The following is a description of a gene set: species: Mus musculus Human Gene Set: GRAESSMANN_RESPONSE_TO_MC_AND_DOXORUBICIN_DN Impairment of the complex regulatory network of cell death and survival is frequently the reason for therapy resistance of breast cancer cells and a major cause of tumor progression. We established two independent cell lines from a fast growing mouse breast tumor (WAP-SVT/t transgenic animal). Cells from one line (ME-A cells) are sensitive to apoptotic stimuli such as growth factor depletion or treatment with antitumor agents (e.g. doxorubicin). Cells from the second line (ME-C cells), which carry a missense mutation at the p53 codon 242, are very insensitive to apoptotic stimuli. Co-cultivation experiments revealed that the ME-C cells mediate cell death resistance to the ME-A cells. Microarray and Western blot analysis showed that osteopontin (OPN) is selectively overexpressed by the ME-C cells. This glycoprotein is the most abundant protein secreted by the ME-C cells and we obtained strong indications that OPN is the main antiapoptotic factor. However, the OPN containing ME-C cell medium does not alter the expression level of pro- or antiapoptotic genes or known inhibitors of apoptosis (IAPs). Its signaling involves mitogen-activated protein kinase (MAPK)/extracellular signal-regulated kinase (ERK) kinase (MEK)1/2 as the kinase inhibitor PD98059 restores apoptosis but not the Akt inhibitor. In the ME-A cells, mitochondrial cytochrome c release occurs with and without external apoptotic stimuli. OPN containing ME-C cell medium does not prevent the mitochondrial cytochrome c release and caspase-9 processing. In serum starved ME-A cells, the OPN containing ME-C cell medium prevents caspase-3 activation. However, in doxorubicin-treated cells, although apoptosis is blocked, it does not inhibit caspase-3. This indicates that the ME-A cells distinguish between the initial apoptotic stimuli and that the cells possess a further uncharacterized control element acting downstream from caspase-3. from publication Graessmann M, Berg B, Fuchs B, Klein A, Graessmann A (PMID 17160024) Genes down-regulated in ME-A cells (breast cancer, sensitive to apoptotic stimuli) exposed to doxorubicin in the presence of medium concentrate (MC) from ME-C cells (breast cancer, resistant to apoptotic stimuli)., and this is the list of marker genes: CYB5B, STEAP4, HNRNPL, SNHG16, CNOT6, GALK1, RFXANK, NT5C3B, DTNBP1, ETF1, PHF21A, MYG1, MRPL3, EEF1E1, NSMCE1 (NCBI Gene Id 197370), GFPT1, TMLHE, C11orf52, TSEN15, ERLIN1, AGFG2, GDI1, FSTL1, TBRG4, DNAJB12, TMEM60, WDR13, ALDH18A1 (aldehyde dehydrogenase 18 family member A1), NFYC, OXSM, EIF2S2, SPAG7, RP2, NUBP1, IL1R1, VPS72, TBC1D19, CYP4F8 (cytochrome P450 family 4 subfamily F member 8), BCL3, BBS9, KAT2A, ILF3, COMMD2, PABIR1, HEATR1, DBN1, DPH6, ME2, TSPAN2, EPS8L3, CEP41, PEX14, SPEN, PUM3, LYPLAL1, IFRD2, EPN2, TCOF1, MINPP1, ERG28, TIMM10, ZFP82, TOMM5, PTDSS2, MRRF, CZIB, CYB5R1, SYNCRIP, BNIP1, MRPL32, IBTK, DCTN4, AP1G1, CEBPB, SH3RF1, DDX10, NR2C1 (nuclear receptor subfamily 2 group C member 1), RUNX1, IP6K1, GNPNAT1, FASTKD2, ZNF212 (zinc finger protein 212), MED16, INTS7, POLR1B (NCBI Gene Id 88998), CHAC2, PAK3, CAT, PSMG1, NECTIN2, RGS19, TDP1, UBE2D3, THSD1, CSNK1D, ACIN1, COQ5, DGCR8, BCCIP, PHKA1, C1QTNF12, PCID2, POLR2I, CSNK2A1, BTN1A1, TMEM161A, KRI1, TPK1, TRIP4 (NCBI Gene Id 9325), TAOK1, PSIP1, TMEM126A, D2HGDH, FOXJ3, MDFI, IMMT, ATF4, KHDRBS1, FNDC4, HSPA4, MORF4L2 (mortality factor 4 like 2), EIF4A2, NSFL1C, TRAF2, TIA1, ENOX2, ZBTB17, PPAT, UBE2G2, BET1 (Bet1 golgi vesicular membrane trafficking protein, NCBI Gene Id 10282), CSTF2, STARD4, BCL2L2 (BCL2 like 2), RBM18, FAR1, NKD2, USP4, UBA3, TRIP11, NOP56, CD44, U2AF1L4, SKP2, TAF1D, CHMP1B2P, FERMT2, PMPCB, TCERG1, RAB4B, CCDC9, CSTF3, MBD3, SOX6, FAM220A, ERC1, PSENEN, DYNLT1, YWHAZ, RITA1, EIF4B, FOXM1, VPS54, SRSF6, SLC23A2, ARGLU1, SARNP, RPL30, TRIM16, SINHCAF, RHOU, GSR, ZNF790, ELAC2, NUTF2, ERI2, CILK1, IPO8, CGNL1, ZSCAN12, RABIF, MMACHC, CPT1B, KLHL7, RASSF1, TBL2, DARS1, LRRC8C, TRIL (NCBI Gene Id 9865), AATF, EPB41L2, PPP4R3A, NEURL4, ZMYM6, DHPS, SOCS2, TTI2, DCP1A, HEXD, SLC46A1, ROR1, KRCC1, GCSH, AP3M2, COX17, CEBPG, HJURP, CCDC43, RNF214, JTB, GCNT1, ZNF22, TIMELESS, EIF4A1, SNAPIN, CDK5RAP1, TUBB, APEX1, HNRNPDL, ZNF644, ZKSCAN3, LMNB2, C6orf136, BPNT1, RRP15, SGTB (small glutamine rich tetratricopeptide repeat co-chaperone beta), BTBD3, MTHFS, YES1, RPP40 (NCBI Gene Id 10799), FANCM, SLC29A2, TCP1, HSPA9, MARCKSL1, SLC9B1, DRAM2, RUSF1, DCPS, PTBP3, ENSA, RILPL2, WDR75, TRIB1, RUFY3, GAS5, ABCC1, DTL, NUP133, ADAT2, RPL3, MAP2K7, ZBED3, GLYCAM1, ALG3, FOXN2 (NCBI Gene Id 3344), CBX1, UBE2S, DCAF8, NR1D2, AKAP12, TMEM167A, CNOT2, C11orf98, RBM10, PCGF2, MLLT10, MT1F, WDR4, XPR1, PAGR1, MOSPD2, METTL1, PDSS1, FOXK2, SUPT20H, DHODH, TOMM40, DTX3, SKA1, POLR1H, HMBS, FARSB, PUS3, LOXL4, USP22, PRPF31, POLR3A, ACBD6, HMBOX1, ZNF329, COIL, DUSP11, SRSF1, PMF1 (polyamine modulated factor 1), STAMBPL1, SEMA6D, MSN, WDFY3, CD2AP, CDC73, PSMD11, XPO4, C1D, ATP5F1C, POMK, UQCC4, ZNF771, TIMM9, CD200, MYBBP1A, ZDHHC5, PPIH, GPAM, PTPRS, LANCL2, SSBP1, ARF6, SNORD22, PIPOX, ACTB, SRPRB, ST13, BORCS7, RAD23A (NCBI Gene Id 5886), FAIM, TP53I13, NOP58, NICN1, NDUFAF4, ELK1, HERC4, KLHL20, HIVEP3, BRD8, RHBDD1, ADAM17, SP3, PBX2, MAD2L2, BCL7B, PQBP1, DSG2, PDHA1, DIMT1, STAT5B, SMR3B, TCF3, POT1, RBM39, GEMIN6, TMEM39A, POLD1, ARPC1B, NUDCD1, RPP21, ELAC1, MSH3, ADAMTSL5 (NCBI Gene Id 339366), NRAS, KRBA1, PLEKHG5 (pleckstrin homology and RhoGEF domain containing G5), ZFAND3, ETAA1, RCCD1 (RCC1 domain containing 1), EXOSC5, MAP4K5, PPP2R1B, PTRH2, GMNN, ZCCHC8, TRUB2, RLIM, ABCB7, NUP58, RAB3D, TBC1D17, AKAP8, FUBP1, ARID4B, PAPOLA, YAE1, DMAC1, NXT1, YEATS4, TRMT112, KMT5B, DHDDS, SCAMP4, ZSCAN22, GDPD1, PPDPF, PPIL4, RBL1, MCM2 (minichromosome maintenance complex component 2), CDCA7 (cell division cycle associated 7), SMIM10L1, ZDHHC3, CNOT7, MAP3K4, PSMG4, ZNF277, FBXW11, RPP14, ZBTB22, ZNF768, FAM118A, RABGGTB, VANGL2 (VANGL planar cell polarity protein 2), ZNF142, USP34, CAPRIN1, RCL1, PIGP, RBBP9, EXOSC2, MTHFD2 (methylenetetrahydrofolate dehydrogenase (NADP+ dependent) 2, methenyltetrahydrofolate cyclohydrolase), CELA1, SEH1L, COQ3, SNRNP40, NUDT16L1, MDP1, LDLR, LBR, BLOC1S5, BRAT1 (NCBI Gene Id 221927), TEFM, HIP1, TMPO, LPCAT1 (NCBI Gene Id 79888), F2RL1, SFR1, SLC25A13, CDK2, POLI, KLF6, TWF1, HCFC1, BCL9, TIMP3, EHD2, STK3, BCLAF1, ARL6IP5, SPIN1, RAB4A, NISCH, RRM1, MAGOHB, MRPL58, DEPTOR, CHD4, MYNN (NCBI Gene Id 55892, myoneurin), RAD23B, MBD2, FKBP11, UBE2J1 (ubiquitin conjugating enzyme E2 J1), CDC6 (cell division cycle 6), CNN3, SLC25A10, FJX1, RCE1, UBAP2L, GRHL2, BYSL, RIPK1, GNL1, CDK16, PPP2R3A, EIF4E2 (eukaryotic translation initiation factor 4E family member 2), SSR1, NASP, PLSCR1, NOTCH4, PTRHD1, PHF12, DHX9, RFC1, RRP8, NELFA, DHX36, ATE1, COA7, NOP10, EXOSC7, MCCC2, HNRNPA1L2, CIP2A, NFIB, SUV39H1, SPOP, SIN3A, PRMT2, ESS2, IRF3, TAF8, RUSC2 (NCBI Gene Id 9853), PHIP, CYP2C18, IER3, HMGA2, TTC8, SMARCE1, ZDHHC6, APBB1, EARS2, GRTP1, ATF6, GYS1, FIGNL1, IPP, ZEB2, FTO, SC5D, NT5E, GNA12, PELP1, HELLS, RAVER1, TPBG, SEC24D, CCSAP, ABCE1, SLC39A11, NFIC, TYMS, SREK1, BCS1L, DNAJC14, MYC, STAM2, WDR77, IL6ST, CEP152, CCNQ, SFXN1, TMEM268, CNEP1R1, GEMIN2, CCL20, EXOC6, TMEM209, ZNF235, ANKRD28 (NCBI Gene Id 23243), TFRC, GPR35, TRMT1L, TRDMT1, PEX11A, CHD1L, DHCR24, DCAF1, PRPF39, CDKAL1, MRPL12, SFN, P2RX4, OGT, HMGXB4, DAZAP1, CXCL6 (C-X-C motif chemokine ligand 6), ARMCX1, KITLG, MTMR2, VAMP3, PARD6B, PAICS, MPHOSPH10, GOLPH3, IARS1, TMEM186, PTPN21, CTTN, PLP2, CFAP298, EXOSC1, CCL5, PDGFRA, PLD2, ELP2, ACVR1B, KPNA3, CASC3, IL13RA1, MRPL19, TIMM44, MTF2, SENP1, USP36, MRPL50, PIGU, CCN5, DPAGT1, METTL22, POLD2, ENC1, RYK, RAD51C, NF2, ERCC4, LIG3, IL15RA, POLD3, ACHE, MDN1, CPNE1, SNRNP48, TOM1L1, PLK4, CBX3, SRSF10, PNN, ZIK1, ZNF207, OCEL1, SUOX, VTI1A, ARHGAP5, SNHG5, OSBPL9, FXN, SPDEF, TRAF6, NSMCE4A, TFAP4, C1QBP, TXNRD3, RSC1A1, NAA15, GMFB, DMAC2, PPP1CC, CXorf38, HSPA8, MAP2, SLC39A3, TNS2 (NCBI Gene Id 23371), HPS1, PIK3C3, EID1, MTAP, PCDHB18P, RAI14, NORAD, POLR1A (RNA polymerase I subunit A), NCK2, POLR3F, EXOSC10, MTBP, LMBR1, ARHGEF10, DTYMK, WAC, THOP1, VASP (vasodilator stimulated phosphoprotein), SLC4A3, RPL41, PTPRF, ANAPC4, ORC3, ERBB2, POLE, TCF7L2 (NCBI Gene Id 6934), OPHN1, FER, RFK, GOT1, IKBKB, HDAC7, ZBTB14, CYP1B1, RUNX2, DGCR2, TUBB2B, SNX5, EEF1AKMT1, HSPBP1, DUSP12, NCAPG2 (non-SMC condensin II complex subunit G2), PHYKPL, STAT5A, POU2F1, SPTAN1, KEAP1, TCTN3, PRKD3, TOE1, USE1, TARS1, PARP2, OSMR, PBK, CLCF1, SLC9A8, GHDC, RNASEH1, PCNX3, FOXP1, TXNIP, VSX2, VRK3 (VRK serine/threonine kinase 3), IVNS1ABP, UTP25, TMEM168, TK1, TRIP13, TPM3, PEAK1, KPNB1, POLR1HASP, SRSF2, COPS7A (COP9 signalosome subunit 7A), FBXW2, FRMD4B, MRPS5, GART (phosphoribosylglycinamide formyltransferase, phosphoribosylglycinamide synthetase, phosphoribosylaminoimidazole synthetase), ADCK1, ERCC6L2, KICS2, ATXN7L3, DDX19B, DNM1L, SEC14L1, SHKBP1, SOCS6, ADISSP, GTF2IRD1, CSDE1, MUTYH, URI1, C19orf44, MGA, HIBCH, STX8, KLHL5, PLEKHF1, CETN3, TMEM216, PIGO, ZBTB12, TRIB3, CPTP, LUC7L2, C5orf34, TARS2, MAPK3, SLC35A3, GTPBP2, SNHG6, ADAT1, ZNF280C, GORASP2, SRSF7, LMF1, PABPN1, ZNF292, NOTCH2, FAAH, ITGA5, POLB, NUMB, BNIP3L, POFUT1, CFAP97 (NCBI Gene Id 57587), SMYD5, DCTPP1, WDR82, CCDC102A, GATB, NOLC1, VTI1B, FOSL2, OPA3, FLOT1